Given this list of marker genes DHFR, NOVA2, TYMS, ETF1, SRSF4, RBM24, LIN28A, DHFRP1 (dihydrofolate reductase pseudogene 1), DHX9, SRSF3, NOVA1, SHFL, LARP6, SSB, FMR1, here is a description of the gene set: Human Gene Set: GOMF_SEQUENCE_SPECIFIC_MRNA_BINDING studied in species Homo sapiens Binding to messenger RNA (mRNA) of a specific nucleotide composition or a specific sequence motif.